Given this list of marker genes Myo19, Rhot2, Mfn2, Trak1, here is a description of the gene set: This event has been computationally inferred from an event that has been demonstrated in another species.<p>The inference is based on the homology mapping from PANTHER. Briefly, reactions for which all involved PhysicalEntities (in input, output and catalyst) have a mapped orthologue/paralogue (for complexes at least 75% of components must have a mapping) are inferred to the other species. Reactome Pathway: RHOT2 GTPase cycle electronically inferred by orthology from the curated human pathway part of: Miro GTPase Cycle studied in species Mus musculus